The following is a description of a gene set: species: Homo sapiens An defense response against a fungus mediated through an innate immune response. An innate immune response is mediated by germline encoded components that directly recognize components of potential pathogens. Human Gene Set: GOBP_ANTIFUNGAL_INNATE_IMMUNE_RESPONSE, and this is the list of marker genes: CARD9, CLEC4C, FAM3A, CLEC4D (NCBI Gene Id 338339), TRIM62, PLCG2 (NCBI Gene Id 5336), RNASE8, BCL10, DEFB106B, DEFB4A, CLEC4E, DEFB114, DEFB106A, CLEC7A, PLA2G5, USP15, RARRES2, CX3CR1, CLEC4A, CLEC6A, DEFB119, DEFB136, SPI1